The following is a description of a gene set: studied in species Homo sapiens Genes having at least one occurrence of the motif NAACNGNCN in the regions spanning 4 kb centered on their transcription starting sites. This matches the MYB transcription factor binding site V$MYB_Q5_01 (v7.4 TRANSFAC). Human Gene Set: MYB_Q5_01, and this is the list of marker genes: EPB41, AK2, SEMA6D, DDR2, C21orf58 (NCBI Gene Id 54058), MDM1, RASA3, PIK3CG, IL11RA, GNAT1, DOCK1, GNL1, CREB5, SRGAP2, CANX, PRRG4, PPARGC1B (NCBI Gene Id 153346), CRTC2, ARHGEF6, ESRRA, SLC16A6, RFX4, ADAM2, RUNX1T1, HTR2C, SARM1, CADM1, RBM39, MXD3, SHKBP1, MTRFR, DENND4A, DMD, NR6A1, HEBP1, SIX4, CLTRN, MROH2B, UBE3A, ZSWIM2, PIAS1, MIDEAS, PRICKLE1, DLX2, TOR1AIP1, XPO1, GCNT2, CACNB3, GNAS, SHMT1 (serine hydroxymethyltransferase 1), WDR82, MAP4, FCRLA, MYOZ2, NMUR1, GPR22, TNNI1, TOX2, LHX6, COMMD3, SRSF5, GMPR2, WNT3, OMG (NCBI Gene Id 4974), GMFG (NCBI Gene Id 9535), ESRRG, ODF4, VAPA, CLDN8, COLEC10, ZNF362, CCND2, NFIL3, ALDOA, CPNE1, GUCA2B, OGDHL (oxoglutarate dehydrogenase L), KIF7, R3HCC1L, SPOCK2, FAP, ZBTB26, BDNF, PPP2R5B, ZNF263, CNTN4, ONECUT1, CDCA3, RDH11, HSPA9, COX7A2P2, VCPKMT, OCRL, MYO18B, AFF4, ABHD2, PIGH, MBD6, ZNF800, STT3B, YWHAE, HHEX, FAM186B, ARHGAP12, PTMS, LUC7L3, NEUROD6, PCYT2, CSDE1, MLN, BRME1, CEBPB, SEC16B, PPP4R4, ANKRD28, RGS2, RPL4, ELAVL4, MDGA2, KMT2D, VN1R3, CAMK2A, KMT2E, DDIT3, SPAG9, KRT25, TMED2, KLF12, C11orf16, FST, SKIDA1, FIGN, TCF12, PREB, GTF3C2, MAEL, MYL6B, DACT1, FAF2, GRK5, PRR3, LNPEP, PLXNC1, UBE2H, ODF2, ANKRD17, NR2F1 (nuclear receptor subfamily 2 group F member 1), CDK2, FRAS1, LEP, ZNF462, BHLHE22, SPATA8 (NCBI Gene Id 145946), CAPN11, CFAP69, NR3C2, MYO18A, MINDY1, SNX6, CHP2, WIPI1, NDUFC1, CDH20 (NCBI Gene Id 28316), ERRFI1, TMEM97, SLC22A11, FGF13, CDK14, MPRIP, LIG4, WBP2NL, FOXP2, RIN1 (Ras and Rab interactor 1), HOXB3, AP5B1, KIF20A, ADGRG4, FLI1, PRKACA, RFX3, PCNT, HRH4, MGLL, FAM91A1, ASIC2, SLC37A1, LTBP1, HES6, RBM14, PGM1, PNOC, ACTC1, KLF5, CCDC171, PSMA1, B3GALT2, PDE3B, SOX5, HMGA2, ZNF296, CPNE6, PLA2G6, NRGN (NCBI Gene Id 4900), OAZ2, TUG1, BEND4, GNG3, TMEM62, USP5, HCN1, JPH3, CRISPLD1, FMOD, CCL5, GPHN, SEPTIN12, SEMA7A, NDEL1, KAT6A, WNT5A, NRG1, PTCHD4, SLC6A9, PCDH9, P2RY2, SMARCA2, PMEL, RAPSN, SSBP2, RHOC, ZMYND8, RPRD2, TASL, DNAAF3, C19orf47, SLC9A7, HMGN2P46, RHOBTB3, BRD8, XPO7, CNTF, PNMA1, FAM181A, PRUNE1, SYNM, PCSK1N, HNRNPF, SYVN1, MANF, ORMDL2, BEST3, NEDD8, SRSF2, FGF12, LRFN5, DNAH12, COQ10B, PRPF38B, IFT57, ETV4, TEX47, DSCAM, G3BP2, RREB1, ING3, RARG, ADAMTS3, BSCL2, RIMS1